Given this list of marker genes Sele, Gcnt1, Capn1, Ptafr, Gp1ba (NCBI Gene Id 14723), Pawr, Ccr2 (C-C motif chemokine receptor 2), Fut7, Fut4, St3gal4, Chst4, Elane, Itga4, Chst2, Selp, here is a description of the gene set: Mouse Gene Set: GOBP_POSITIVE_REGULATION_OF_LEUKOCYTE_TETHERING_OR_ROLLING Any process that activates or increases the frequency, rate or extent of leukocyte tethering or rolling. studied in species Mus musculus